The following is a description of a gene set: Human Gene Set: HP_PANCREATIC_CYSTS Pancreatic cysts species: Homo sapiens A cyst of the pancreas that possess a lining of mucous epithelium., and this is the list of marker genes: BICC1 (BicC family RNA binding protein 1), ALG9, XPNPEP3, CCND1, ZMYM3, TMEM231, VHL, OFD1, ALG5, TMEM107, TXNDC15, TCTN1, MKS1, PKD2, B9D2, RBM8A, B9D1, CC2D2A, TMEM216, CEP290, CSPP1, GLIS3, TCTN3, IFT140, RPGRIP1, GANAB, NPHP3, TCTN2, PKHD1, TMEM67, PKD1, TMEM237, WDR19 (NCBI Gene Id 80203), RPGRIP1L, DNAJB11, DZIP1L